The following is a description of a gene set: Human Gene Set: GSE17721_POLYIC_VS_GARDIQUIMOD_2H_BMDC_UP mouse primary BMDCs were stimulated with tlr ligands and gene expression changes were profiled on Affymetrix arrays Genes up-regulated in comparison of dendritic cells (DC) stimulated with poly(I:C) (TLR3 agonist) at 2 h versus DC cells stimulated with Gardiquimod (TLR7 agonist) at 2 h. studied in species Homo sapiens from publication Amit I, Garber M, Chevrier N, Leite AP, Donner Y, Eisenhaure T, Guttman M, Grenier JK, Li W, Zuk O, Schubert LA, Birditt B, Shay T, Goren A, Zhang X, Smith Z, Deering R, McDonald RC, Cabili M, Bernstein BE, Rinn JL, Meissner A, Root DE, Hacohen N, Regev A (PMID 19729616), and this is the list of marker genes: METTL25B, POLD1, SLC3A2, DUSP6, CYBC1, AMMECR1L, GIGYF1, TIA1, MAF1, NKX2-8, KDM6A, GP2, IFIT3, COQ8A, TSPAN5, UBE2G2, TSEN15, MLLT10, RS1 (retinoschisin 1), RALBP1, ANKRD10, RNF181, TCOF1, PRP4K, ZBED4, GFUS, MED22, GGPS1, NOL7, EEF1B2, BLTP3B, SPRED2, CAPN2, GCM1, KREMEN1 (kringle containing transmembrane protein 1), BRWD3, ELF2, ERCC6L, ZFP36L2, LPIN1, CXorf38, ENTPD4, RIOX1 (NCBI Gene Id 79697), KLF4, ABHD18, TREX1, ENDOD1, KLHL13, KRTAP15-1, ATP13A2, SON, HOPX, MYC, CA5B, TUBB2B, CLN8, NSMCE4A, SMC4, IRF5, GREM1, SERTAD1, FAM120A, RAB40C, TDP2, SERPING1, CNR2, BCLAF1, EIF2AK2, ATRX, CD99L2, CAVIN3, DSP, MAST3, TMEM131L, PLEKHB1, ESF1, TMEM209, HACD2, TOR4A, MAFB, PTS, MAN2C1, H6PD, HBA2, ANKS3, P3H3, B9D2, SERHL2, EARS2, NT5C3A, ACSL6, HASPIN, KRT33B, RAI14, WIPF1, MAP3K3, TIPARP, TOPBP1, SCAND1, EMP3, DNA2, RPLP1, ASF1A (anti-silencing function 1A histone chaperone), MBD4, TAMALIN, PEX16, TFPT, CIPC, TRMT1L, PTGIR, BLMH (NCBI Gene Id 642), EVI5, FDFT1, S100A6, ACSS2, NOTCH2, GRIA2, ODR4, EVI2B, OAS2, DUSP7, ISG15, ITPR2, ANP32B, ATG9B, DTL, RBMS1, MAGI2, AP2A2, KLF16, KRTAP13-2, TMEM51, PAG1, LSM1, TSPAN14, MTSS1, CCND3, NRGN, ANXA9, TMUB2, CASP3, RGS19, MITD1, ZSCAN26, KANSL2, RPL26, RWDD3, ABTB1, RBM43, REEP3 (NCBI Gene Id 221035), NEURL4, MFSD3, GSK3B, CCDC136, TMEM115, KCNH2 (NCBI Gene Id 4027), BIRC2, CPSF4, COMMD9, TPRKB, TAPBP (NCBI Gene Id 6892), TBC1D20, MXRA8, MC1R, RPGRIP1, ZNF830, RAB4A, KLHDC3, NABP1, BHLHE41, BOLA2, RPL7, DMAP1, PHAX, SIL1, TMEM140, TRMT10C, PDE6A, LTBP3, FAM111A, DAXX, TMEM219, SMIM7, USP19, SMARCAL1, FGF20, KCNN4, ZNF426, GEMIN6, DOC2A, TGFB1I1, JUN, SPEN, PSMB1, ARID1A, SOX5, SPEF1, RGL2, SHPRH, DDX18 (DEAD-box helicase 18)